Given this list of marker genes Arfgef2, H2-T23, Lgals9, Lrrk2, Lrrfip2 (NCBI Gene Id 71268), Arhgef2, Spon2, Cd84, Ifngr1 (interferon gamma receptor 1), Tlr4, Nfatc4, Cybb, Lbp, Cd2, Ptpn11, Oas1d, Il33, App, Oas3, Arid5a, Oas1g, Spn, Ccr7, Oas1h (NCBI Gene Id 246729), Ager, Ccr5, Ripk1, Ly96, Havcr2, Nod1, Ptafr, Zbtb20, Frmd8, Tlr9, Twist1, Lpl, Wnt5a, Setd4, Il18, Il23a, Stat3, Selenok, Ccl2, Isl1, Card9, Dhx9 (DExH-box helicase 9), Oas1f, Hspd1, Csf1r, Hmgb1, Lilra5, Ncl, C1qtnf4, Pten, Fcer1g, Hspb1, Sphk2, Ripk2, Jak2, Clu, Adam8, Mapkapk2, Ifih1, Lep, Oas1b, Tnfrsf1a, Adam17, Mif, Myd88, Oas1e, Fcgr3, Cd14 (CD14 antigen), Abcc8, Ccl3, Ifng, Ticam1, Ccr2, Tmem106a, Mmp8, Rigi, Thbs1, Psen1, Ccl19, Ephb2, Cyp2j6, Oas1a, Pik3r1, Akap12, Sash3, Ptprc, Clec7a, Il17f, Syk, Hdac2, Oas1c, Rasgrp1, Cd209b, Tgfb1, Ccl4, Fadd, Tirap, Fcgr1, Il6, Oas2, Il1a, Ptprj, Cyba, Tlr2, Cd36, Il12b (interleukin 12b), Nod2, Tyrobp, Tlr3, Plcg2, Fzd5, Il17a, Ccn1, Btk, Tlr1, Mavs, Tnfrsf8, Fcgr2b (NCBI Gene Id 98391), Pycard, here is a description of the gene set: Any process that activates or increases the frequency, rate or extent of tumor necrosis factor superfamily cytokine production. studied in species Mus musculus Mouse Gene Set: GOBP_POSITIVE_REGULATION_OF_TUMOR_NECROSIS_FACTOR_SUPERFAMILY_CYTOKINE_PRODUCTION